The following is a description of a gene set: The SLC39 gene family encode zinc transporters belonging to the ZIP (Zrt-, Irt-like proteins) family of metal ion transporters. All ZIPs transport metal ions into the cytoplasm of cells, be it across cellular membranes or from intracellular compartments. To date, there are 14 human SLC39 genes that encode the zinc transporters hZIP1-14. There are 9 members which belong to a subfamily of the ZIPs called the LZTs (LIV-1 subfamily of ZIP zinc transporters) (Taylor KM and Nicholson RI, 2003). Of these 14 proteins, four (hZIP9, 11, 12 and 13) have no function determined yet (Eide DJ, 2004). studied in species Homo sapiens Reactome Pathway: Zinc influx into cells by the SLC39 gene family part of: Zinc transporters, and this is the list of marker genes: SLC39A10, SLC39A6, SLC39A5, SLC39A4, SLC39A14 (NCBI Gene Id 23516), SLC39A8, SLC39A1, SLC39A7, SLC39A2, SLC39A3